Given this list of marker genes MAP1B, RIN1, GATA2, MMRN1, ISG15, MC1R, KLRK1, CRADD, GP9, TNFSF10, LYL1, THBD, IFI27, ICAM2, SERPINB1, KLRC1, H1-10, PLOD2 (procollagen-lysine,2-oxoglutarate 5-dioxygenase 2), IFI6, AKR1B1, GAL, TBXAS1, FXR2, ZBTB48, OAS2 (2'-5'-oligoadenylate synthetase 2), PFN2, MYC, ITGB5, GJA1, FOXO1, A2M, SULT1A3, here is a description of the gene set: Genes down-regulated in KCL22 cells (chronic myelogenous leukemia, CML, with BCR-ABL1 fusion) by expression of CEBPA. Human Gene Set: TAVOR_CEBPA_TARGETS_DN from publication Tavor S, Park DJ, Gery S, Vuong PT, Gombart AF, Koeffler HP (PMID 14517214) species: Homo sapiens The transcription factor C/EBPalpha plays a critical role in the process of granulocytic differentiation. Recently, mutations that abrogated transcriptional activation of C/EBPalpha were detected in acute myeloid leukemia patient samples. Moreover, the progression of chronic myelogenous leukemia (CML) to blast crisis in patients was correlated with down-modulation of C/EBPalpha. The KCL22 cell line, derived from BCR-ABL+ CML in blast crisis, expressed wild-type C/EBPepsilon protein but not a functional C/EBPalpha, -beta, and -gamma. Restoration of C/EBPalpha expression in KCL22 cells triggered a profound proliferative arrest, a block in the G2/M phase of the cell cycle and a gradual increase in apoptosis. Within 3 days of inducing expression of C/EBPalpha, a remarkable neutrophilic differentiation of the KCL22 blast cells occurred as shown by morphologic changes, induction of expression of CD11b, primary, secondary, and tertiary granule proteins, and granulocyte colony-stimulating factor receptor. Using high density oligonucleotide microarrays, the gene expression profile of KCL22 cells stably transfected with C/EBPalpha was compared with that of empty vector, and we identified genes not previously known to be regulated by C/EBPalpha. These included the up-regulation of those genes important for regulation of hematopoietic stem cell homing, granulocytic differentiation, and cell cycle, whereas down-regulation occurred for genes coding for signaling molecules and transcription factors that are implicated in regulation of proliferation and differentiation of hematopoietic cells. Our study showed that restoration of C/EBPalpha expression in BCR-ABL+ leukemic cells in blast crisis is sufficient for rapid neutrophil differentiation suggesting a potential therapeutic role for ectopic transfer of C/EBPalpha in acute phase of CML.